The following is a description of a gene set: The operation of the mind by which an organism becomes aware of objects of thought or perception; it includes the mental activities associated with thinking, learning, and memory. Human Gene Set: GOBP_COGNITION studied in species Homo sapiens, and this is the list of marker genes: AGER, CCL11 (NCBI Gene Id 6356), RTL4, GLP1R, TACR2, NPTX2, ATP1A2, SLC12A5, ACSS2, SHROOM4, DTNBP1, BLOC1S6, SNAP25 (NCBI Gene Id 6616), ZNF385A, SHANK1 (SH3 and multiple ankyrin repeat domains 1), PRRT1, MDK, MAPT, PRKCA, PLK2, NTF4, C1QL1, DLG4, CEBPA, NTRK2, PLN, CYFIP1, INS, FEN1 (flap structure-specific endonuclease 1), GPR155, NEUROD2, EN1, GABRA5 (gamma-aminobutyric acid type A receptor subunit alpha5), RELN, CLDN5, TACR1, FAM107A, CIC, GHSR (growth hormone secretagogue receptor), PTPRZ1, FZD9, COMT, LDLR, CNTN2, ARC, PICALM, METTL23 (NCBI Gene Id 124512), HMGCR, B2M, PGRMC1, JPH3, SYNJ1, FOXP2 (forkhead box P2), TMOD2, ATP8A1, SHANK2, KIAA0319, EPM2A, ADAM2, PPP3CB, ITGB1, CRTC1, FGF13, PPT1 (palmitoyl-protein thioesterase 1), EIF2AK4, CHRNA7, TANC1, KCNK2, KAT2B, NRGN, MECP2, TACO1, ATAD1, SLC6A3, GMFB, GPRASP3, NETO1, WASHC4, MAP1A, POMK, MAPK1, BBS4, PDE1B, TLR2, CEBPB, NRXN1, SETD5, KRAS, IFT20, PPP1R1B, B3GAT1, NTAN1, NLGN4X, DRD5, THRA, TNR, ADGRF1, PTEN, TBR1, CUX2, SLC6A1, MAPK8IP2, GRIN2B, DBH, BTBD9, GALR2, AAAS, ADNP, CLSTN2, ROGDI, PPP1R9B, MAGT1, CPEB3, TAFA2, NEUROG1, NPS, ADORA1, S100B, SHANK3, SLC1A1, PAK6, EIF4EBP2, NF1, PRKN, GAREM2, NDRG4, SORCS3, SLC24A2, PSEN1, GPI, SCN2A, SYNGAP1, CHD7 (chromodomain helicase DNA binding protein 7), CHRNB2, OPRK1, NLGN4Y, STRA6, RGS14, NCSTN (NCBI Gene Id 57297), CHMP2B, MAN2B1, SPG11, BGLAP, APP, CHRNA4, NSUN5, GATM, ADGRB3, LHCGR, FYN, ABCA7, GALR3, NIPBL, DEAF1, FOS, SLC11A2, VDAC1, ITPR3, KAT2A, SHISA7, KCTD16, SLITRK4, TTC8, SLC7A11 (NCBI Gene Id 23657), DRD3, LILRB2, NTSR1, KMT2A, CRHBP, TAAR5, C5AR1, SLC6A4 (NCBI Gene Id 6532), UCN, GRIN2A, GRIN1, KLK8 (kallikrein related peptidase 8), YTHDF1, ADCY8, CBR3, TSC1, CAMK4, SOBP, EPHB2, VLDLR, LCN2, ADCY1, PAIP2, CREB1, CASP3 (caspase 3), LINS1, LGMN, SLC17A7, FOXB1, NRXN2, PRKCG, PIANP, HTR2A, NTRK1, BCHE, ITGA8, MGAT3, SERPINF1, TMPRSS11E, APOE, DCAF11, SRF, HTT, GNAS, GMPPA, NOG, GRIA1, CRH, PTN (pleiotrophin), KCNK4, GRPR (gastrin releasing peptide receptor), GIP, CLN3, GRM5, GM2A, GPR88, SLC2A4, CSMD1, CAMK2N1, ABL1, HRH1, GPR158, TUSC3, CHL1, BTG2, LCE1D, DGCR2, MEF2C, TIFAB, NLGN3, DNAAF4, KIT, SPECC1 (NCBI Gene Id 92521), GTF2A1L, GIT1, PAFAH1B1, LMX1A, TAC1, DRD1, C14orf28, PDE8B, FOXO6, AMFR, ARF4, MEIS2, ITGA3, PAK5, VDAC3, CCND2 (NCBI Gene Id 894), RCAN1, DNAH11, ARL6IP5, ASIC1 (acid sensing ion channel subunit 1, NCBI Gene Id 41), NRXN3, PLCB1, CLN8, OR52B4, EP300, LRRN4, CTNS, CHRM1, RP9, OXT, TNF, C12orf57, AFF2, ATXN1, TPBG, HIF1A, SLC8A3, ELAVL4, DOP1B, SLC8A2, RIC8A, TTC36, JPH4, TUBA1A, ABCC8, DDHD2 (NCBI Gene Id 23259), DCANP1, CDK5, BRAF, NEDD9, CALB1, HOXA1, SYT11, EGFR, PTCHD1, PRNP, MFSD2A, INSR, PIAS1, TH, BRSK1, DKK1, RAPGEF3, KCNAB1, DRD2, NFATC4, B4GALT2, TTBK1, ADCY3, PRKAR2B, CHST10, MUSK, NPAS4, SLC1A4, SGK1, GABRB3 (NCBI Gene Id 2562), MME, RCAN2, PJA2, RASGRF1, PRKAR1B, ITGA5, LARGE1, CNTNAP2, RAG1, BRINP1, JAKMIP1 (NCBI Gene Id 152789), TREM2, ATXN1L, HLA-DRA, SYT4 (synaptotagmin 4), EIF4A3, ARMCX5-GPRASP2, VPS13B, ST3GAL4